The following is a description of a gene set: The directed movement of L-glutamate, the L-enantiomer of the anion of 2-aminopentanedioic acid, into a cell or organelle. Mouse Gene Set: GOBP_L_GLUTAMATE_IMPORT studied in species Mus musculus, and this is the list of marker genes: Slc25a12, Tnf, Kcnj8 (NCBI Gene Id 16523), Arhgef11, Slc17a6, Dtnbp1, Slc17a7, Psen1, Slc1a1, Rab3gap1, Kmo, Nf1, Slc7a13, Grm1, Vps54, Slc3a1, Slc1a4, Slc17a8, Ttyh2, Slc7a11, Slc1a6, Ntsr1, Epm2a, Slc25a18, Abcc8, Per2, Slc25a13, Arl6ip1 (ADP-ribosylation factor-like 6 interacting protein 1), Slc38a2, Grik1, Slc1a3, Slc25a22, Stxbp1, Pak1, Arl6ip5, Ttyh1, Septin2, Ttyh3, Cln8, Slc1a2 (NCBI Gene Id 98863), Slc38a6, Itgb1, Slc1a7, Gnat2, Kcnj10 (NCBI Gene Id 16513)